Given this list of marker genes Bmp6, Pak2, Tbcd, Dlg5, Vcl, Cdh13, Tjp1, Mtss1, Cdc42, Src, Cdh26, Numbl, Cdh22, Afdn, Smad7, Add1, Epha4, Cdh18, Cdh20 (NCBI Gene Id 23836), Actb, Fer, Pkp2, Cdh6, Csk, Ramp2, Cdh24 (cadherin-like 24), Ptpn23, Cdh17, Numb, Abi2, Cdh1, Fermt2, Cdh15, Hipk1 (NCBI Gene Id 68849), Rdx, Cdh8, Cdh11, Adam10, Plekha7, Cdh10, Cdh19, Plec, Dsp, Jam3, Ctnnb1, Cdh3, Cdh9, Specc1l, Vegfa, Cdh12, Cdh4, Cdhr18, Zfp703, Inava, Cdh7, Cdh2, Efnb2, Camsap3, Cdh5, Kifc3, here is a description of the gene set: A process that is carried out at the cellular level which results in the assembly, arrangement of constituent parts, or disassembly of an adherens junction. An adherens junction is a cell-cell junction composed of the epithelial cadherin-catenin complex at which the cytoplasmic face of the plasma membrane is attached to actin filaments. Mouse Gene Set: GOBP_ADHERENS_JUNCTION_ORGANIZATION studied in species Mus musculus